The following is a description of a gene set: Genes predicted to be targets of miRBase v22 microRNA mmu_miR_3620_3p in miRDB v6.0 with MirTarget v4 prediction scores > 80 (high confidence targets). species: Mus musculus from publication Chen Y, Wang X (PMID 31504780) Mouse Gene Set: MIR_3620_3P, and this is the list of marker genes: Rngtt, Negr1, Elovl4, Eif5a2, Ap1ar, Map3k2, Tspyl2, Phkb, Ephx3, Trrap, Dach1, Syde1, Scn3b, Chm, Zmym1, Garem1 (GRB2 associated regulator of MAPK1 subtype 1), Acad9, Naa30, Pde1c, Prlr, Ilf3, Cacna1c, Mex3b, Eeig2, Nod2, Tnfsf9, Srsf10, Cyb5r4, Zbtb4, Col27a1, Cse1l, Pabpc1, Htr3a, D16Ertd472e, Chic1 (NCBI Gene Id 331484), Vwc2, Naa15, Ubn2 (ubinuclein 2), Fbxo27, Kat6a, Lpp, Arrb2, Alcam, Pde8b, Sort1, Ciao2a, Ccni, Aox1, Stac, Stox2, Zhx3, Bri3bp, Comtd1, Rorb, Tecrl, Adam5, Sez6l2, Dstyk, Fbxl20, Lrrn3, Onecut2, Caps2, Nudt16l1, Anxa8, Mapk1, Tnfsf4, Retreg3, Dppa1, Dpm1, Ppm1b (protein phosphatase 1B, magnesium dependent, beta isoform), St8sia3, Ttc17, Slc7a11, Bbs1, Ppfia1, Pnoc, Stt3a, Zfp444, Prdm14, Map3k20, Cbarp, Me1, Plag1, Stmn2, Plxnb2, Uggt1, Fam171a1, Trpm3, S100a4